Given this list of marker genes CLUAP1, CDON (cell adhesion associated, oncogene regulated), IFT20, ENPP1, RACK1, SMO, KIF7, FGFR2, TTC21B, C2CD3, CHSY1, POR, RB1, PRRX1, GPC3, MGRN1, SERPINE2, DYNC2H1, IFT81, PTCH1, NKX6-1, TUBD1, NKX2-2, HHIPL1, SKOR2, DCDC2, GORAB, TMED2, GLI2, CTNNA1, SCUBE1, B9D1, IFT27, HERC4, PDX1, HHAT (hedgehog acyltransferase), TMEM17, FKBP8, ARL13B, KCTD21, PTCH2, IHH, GLI1, FBXL17, EFCAB7, CD3E, MKS1, KIAA0586, GLIS2, TUBA1A, NDP, GAS8, RPGRIP1L, INTU (NCBI Gene Id 27152), TTC23, IFT122, HES5 (hes family bHLH transcription factor 5), WDR19, GLI3, PAX6, SLITRK4, NOG, FOXA1, NCOA2, DISP3, KCTD11, SFRP1, OTX2 (orthodenticle homeobox 2), SUFU, FOXF1 (NCBI Gene Id 2294), CPLANE2, VCP, DZIP1, MEGF8, BBS7, TRAF3IP1, TEDC1, GPC2, TCTN1, WDPCP, TEDC2, DLG5, HSPG2, FGF9, HHIP, TXNDC15, IFT56, TTBK2, ACTRT1, UCHL5, STIL, IFT25, IFT172 (intraflagellar transport 172), IFT80, HES1, CIBAR1, DHH, ZIC3, MOSMO, CDK20, PKD2L1, MAP3K10, CFAP410, RUNX2, SHH, ISL1, WNT10B, RORA, PRKACA, KCTD6, DISP1, FUZ, ZIC1, GAS1, EVC, STK36, TGFBR2, GPR161, RAB34, TCTN2, HIPK1, ARL6, PRKACB, PDCL, IFT46, IFT140, IFT52, UBR5, DYRK2 (NCBI Gene Id 8445), TMEM231, ULK3, ARL3, NSDHL, SEPTIN2, DISP2, EXT1, CENPJ, RFX4, PTCHD1, TBC1D32, RO60, IQUB, NDST1, CREBBP, IFT57, WDR11, TCTN3, FGF10, DZIP1L, ARMC9, GPR37L1, TULP3, CC2D2A, BTRC, EVC2, HIPK2, SHOX2, here is a description of the gene set: The series of molecular signals generated as a consequence of activation of the transmembrane protein Smoothened. Human Gene Set: GOBP_SMOOTHENED_SIGNALING_PATHWAY studied in species Homo sapiens